The following is a description of a gene set: from publication Koyama N, Zhang J, Huqun, Miyazawa H, Tanaka T, Su X, Hagiwara K (PMID 18985860) Human Gene Set: KOYAMA_SEMA3B_TARGETS_DN SEMA3B, a member of class 3 semaphorins, is a tumor suppressor. Competition with vascular endothelial growth factor (VEGF)165 explains a portion of the activity, whereas the VEGF-independent mechanism was not elucidated. We employed a microarray and screened for the genes whose expression was increased by SEMA3B in NCI-H1299 cells. Insulin-like growth factor-binding protein-6 (IGFBP-6), a tumor suppressor, showed greatest difference in the expression level. Introduction of IGFBP-6 cDNA reduced colony formation both on the dish surface and in soft agar. Insulin-like growth factor II, which antagonizes IGFBP-6, partly abrogated the effect. Inhibition of IGFBP-6 by small interfering RNA diminished the sub-G0/G1 population that was induced by SEMA3B and abrogated the growth suppressive effect of SEMA3B. We concluded that IGFBP-6 is the effector of tumor suppressor activity of SEMA3B in NCI-H1299 cells. It has been reported that beta-catenin suppresses the expression of IGFBP-6. Introduction of beta-catenin into the cells partly abrogated the growth suppressive effect of SEMA3B. Our result indicates that semaphorin signaling and beta-catenin signaling converge on IGFBP-6 and antithetically affect their functions. Genes down-regulated in NCI-H1299 cells (large cell neuroendocrine carcinoma) stably expressing SEMA3B. studied in species Homo sapiens, and this is the list of marker genes: CENPU, ATP2B1, IPO9, GON4L, SBNO1, EFCAB2, GLRX2, NKD2, NCBP3 (NCBI Gene Id 55421), LUC7L3, TRAF5, COCH, CAV2, ADGRG6, CALB2, BIRC3, FAM120B, RIMBP3, RGS2, UBE2G1, CAMSAP2, PSMB4, XPR1, KLF10, SLC44A3, SHCBP1, TWIST2, PRRT3-AS1, ZDHHC12-DT, NR3C2, LACTB2, ARRB1, LEAP2, BTBD9, IRX3, TDRD9, DPY19L2P2, NQO1, ZNF131, QSER1, TRIQK, TCF4, RBM28, CHCHD7, ZFR2, SMO, CCDC167, ATL1, CD70, POLR1C, ZC2HC1C, STX11, HDAC4 (NCBI Gene Id 9759), TRAF1, LARP7, HSPA1B (heat shock protein family A (Hsp70) member 1B), LNP1, FLVCR1, LIAT1, ZNF775, NFATC1, SYNGR3, TPMT, IMPA2, MIR9-1HG, CCDC28B, GALNS, NECAB2, TRIM6, PRDM6-AS1, DTL, SRPK2, C19orf25, ITFG2 (integrin alpha FG-GAP repeat containing 2), CD40, THEMIS2, PSMB9, TERT, PLEKHF2, GPR153, FZD7, CSPP1, CORO7, KHDRBS3, CNOT1, ZP3 (zona pellucida glycoprotein 3), PIR (NCBI Gene Id 8544), GPATCH4, BROX, ZCCHC14, PHYHIPL, SDHA, NMNAT3, RSBN1, ATP11C, WASL, CBFB (core-binding factor subunit beta), PTGES3 (NCBI Gene Id 10728), HMGN2, CHD7, TAGLN2, ALS2, HIVEP2, ZIM2-AS1, RFX5, PMEPA1, ELFN1, TSGA13, ENSG00000292993, C10orf67, PHF7, LHX6, ID4, XRCC2, DRAP1, CDC73, INSYN2A, DIAPH2, AMIGO2, PPM1E, CUL1 (cullin 1), ADORA2B, NDUFS2, CKS1B, FAM133A, DECR1, CEP350, PLD2, ADM, CRYZL2P, TMEM158, ARID5B, BLTP3B, AIF1L, KITLG, SRSF12, GPAT2, NCAPD2, FBXO32, H2AC20, ACTG1P25, SLC12A7, DPEP3, RASAL2, EXOC4, NFAT5, TTC32, RAB4A (RAB4A, member RAS oncogene family), TAP1 (transporter 1, ATP binding cassette subfamily B member), PEG3, GSTM3, CD47, PGS1, PLK1, INKA2, LYPLA1, DGKD, SLC12A5, PRRX2, CLEC11A, CPEB1, MYO10, TBC1D22A, SSR2, CAV1, CENPN, PRKAA1, PNPLA8, SMAD6, MZF1-AS1, ETS1, SYPL1, HAUS3, SCAMP3, TICRR, KLHL20, DHRS3, CELSR1 (cadherin EGF LAG seven-pass G-type receptor 1), CCDC146, ELOVL2, UQCRC1, TGFB2, LHX2, CDC42SE1, GATA2, NOL11, NLRP3 (NLR family pyrin domain containing 3), CXADR, SERTAD4, ADORA2A, ZNF277, ANKRD7, AKR1B1, TSPAN33, MESP1, TMUB1 (NCBI Gene Id 83590), ID2, KLRA1P, PDIA4, HES1, DDX27, SNRPG, RFLNA, GPC1, C6orf52, PSMA8, TCF7L1, ROR1, SH3YL1, FAM83H, DAP3, SLIT3, SLC6A8 (solute carrier family 6 member 8), NOVA1, IGF2, STAT6, CXXC4, VAMP4, DNAJC21, TNS3, FBLN2, BRAF, MIS18BP1, SRP14-DT, NEFH, LIPT1, TBCE, OSGIN1, ISCU, GRAMD4, PRR5L, GSTM1, CAPZA2, FN1, DLGAP3 (DLG associated protein 3), GSTM4, LRRCC1, ASH1L, ATP8B3, C15orf48, RPL26, CTDSPL, OPN1SW, PDCD6, CCDC92, NEK2 (NCBI Gene Id 4751), CDPF1, DPY19L4, ZNF704, CTSH, EEIG1, KRBA1, RASGEF1A, TTC13, NFKBIA, SPACA9, SOX18, TMEM81, FOXP4, CCT3 (NCBI Gene Id 7203), INSIG1, PLEKHO1, SGO1, SLFN11, PPP2R2C, HLX, NEURL1, KCNG1, SVIL2P, AGK, PRKAR2B, TSPYL5, PLPP4, MPC2, IVNS1ABP, STRIP2, BMP15 (NCBI Gene Id 9210), PARVB, TRIM24, GABARAP, CTSZ, NIPAL2, FZR1, C1orf35, SYNGR1, ZZEF1, KLHDC8B, LMO4, S100A10, ROPN1L, ODAD3, C1QTNF3, KLHL26 (NCBI Gene Id 55295), ATRN, CABLES2, KLF6, MED11, TYW5, MYL9, UBR5, SMARCD3, EFHD1, TRAF3IP1, JAG2, PTPN11, PDE4DIP, MIR1915HG, ZNF862, NDUFA5, HHIPL2, ACYP1, CGN, EFNA1, CALD1, EFEMP2, IFT56, SOBP, ABCD1, RFLNB, PGAP1, SLCO4A1, CCDC159, PANX2, RIMKLA, ANKRD33B, SYNM, NTM, EPHX1 (epoxide hydrolase 1), TBX3, LNC-LBCS, EGFL7, CYP2T1P, TBX2-AS1, CTCFL, SH3BP4, ICOSLG, IRX5, TSACC, CBX7, LITATS1, RPL37, VAPA, GNG4, SVIL, GDNF, DKK1 (dickkopf WNT signaling pathway inhibitor 1), NRAS, TCF15, GBA2, ZNF695, HMGCS1, ENG, FBXL7, PAXIP1, RRAD, ALCAM, FCHO1, JAG1, ITGAM, SYDE2, CALML4, ARFGEF1, SCCPDH, LPP